The following is a description of a gene set: studied in species Homo sapiens Regulatory T (Treg) cells that express the FoxP3 transcription factor are essential for lymphoid homeostasis and immune tolerance to self. Other non-immunological functions of Treg cells, such as controlling metabolic function in adipose tissue, are also emerging. Treg cells originate primarily in the thymus, but can also be elicited from conventional T cells by in vivo exposure to low-dose antigen or homeostatic expansion, or by activation in the presence of TGFβ in vitro. Treg cells are characterized by a distinct transcriptional signature controlled in part, but not solely, by FoxP3. For a better perspective on transcriptional control in Treg cells, we compared gene expression profiles of a broad panel of Treg cells from various origins or anatomical locations. Treg cells generated by different means form different sub-phenotypes identifiable by particular combinations of transcripts, none of which fully encompass the entire Treg signature. Molecules involved in Treg effector function, chemokine receptors, and the transcription factors that control them are differentially represented in these subphenotypes. Treg cells from the gut proved dissimilar to cells elicited by exposure to TGFβ, but instead they resembled a CD103+Klrg1+ subphenotype preferentially generated in response to lymphopenia. from publication Feuerer M, Hill JA, Kretschmer K, von Boehmer H, Mathis D, Benoist C (PMID 20231436) Human Gene Set: GSE20366_CD103_KLRG1_DP_VS_DN_TREG_DN Genes down-regulated in comparison of TregCD103-Klrg1- versus TregCD103+Klrg1+ (see Table 1S in the paper for details)., and this is the list of marker genes: DES, MAGEH1, IKZF3, FMNL2, SLC35D2, SERPINB7, BSPRY, FARP1, PHLPP2, CDCA5, HLA-C, YES1, CD244, MTMR10, ADAM9, INTS7, RFK, CEMIP2, HIP1, HLF, NUPR2, USP28, SLC43A2, NXPE4, EPCAM, ASAH1 (N-acylsphingosine amidohydrolase 1), SLC25A19, CHDH, CD70, KCNK6, KDELR2, DYNLT5, APH1B, NPNT, OBI1, VAMP7, RPGR, PHYKPL, GTPBP3, CDC14B, STXBP1, BTBD19, APPL2, INTS13, GNPDA1, GLRX2, MAP3K20, ATOSB, NOL10, NUCB2, BRWD1, CWC25, UEVLD, CELF5, ACOT11, SRGN, TAF15, CRYBA4, ALMS1, ANXA4, LPGAT1, DUSP3, HYCC1, LIX1L, IRF5, MYO1F, IRAK3, NPC1, FUT9, B3GNTL1, ZFAND4, TTC39C, TSPOAP1, SLBP, CDKN2C, SELENOM, RNF157, PAQR8, STMN3, GNAQ, LGMN, ALDH9A1, CSRP2, CYB561, MAP4, CORO2B, PLEKHA8, ZNF600, SNX2, RPS6KA5, CRYBG3, ALOX15B, CKLF, IL10, TWF1, MAN2A1, ALPK2, UBL3, GSTT1, TMEM263, FZD5, ELL2, CXCR3, GMPR, CHSY1, SYTL2, SLC5A12, DLK1, KIF5C, ARSB, KIF13B, ZCCHC18, PTPRJ, SCO1, TBC1D5, DUSP1, CDKL2, PPM1D, NLN, ENO2, SEC11C, TPP1 (tripeptidyl peptidase 1), ST6GALNAC6, CIAO2A, OPTN, GPR155, KRT72, SPIN1 (NCBI Gene Id 95616), IFNG, RTKN, CLDN12, ABCB1, NBEA, PACRG (parkin coregulated), ICOS, ARHGAP11A, REXO5, RASSF4, APOBEC3B, SNX16, ARHGAP21, STK40, CCDC117, DSN1, EHD1, VCL, CTSH, SNX9, CEBPZOS, EEA1, CCR6, SEPTIN10, TERB1, MTHFS, CAB39, TRAPPC14, HNRNPLL, HBP1, SHISA3, GLIPR1, GRINA, MMP9, WEE1 (WEE1 G2 checkpoint kinase), WNK1, GPAT3, CHMP4C, TC2N, RHBDD1, ITM2B, DZANK1, ZNF490, DYNLT2B, MASP2, RAB31, PDE2A, LMNB1, PTPN3, NIPA2 (NCBI Gene Id 96367), NUDT4, AP3M1, DMXL2, GPR68, RYK, CIITA, DCUN1D4, LPCAT1, CCNG1, FXYD6, ZIK1, SHCBP1L, PRR13, NQO1, CASS4, PBX3 (PBX homeobox 3), TF, AGPAT4, SKAP2, TMBIM1, CCDC71L, FUT8